Given this list of marker genes Tbc1d4, Furin, Cnksr1, Pi4k2b, Prdm16, Hes1, Ccdc136, Rslcan18, Pdp1, Crcp, Rph3al, here is a description of the gene set: Genes predicted to be targets of miRBase v22 microRNA mmu_miR_8117 in miRDB v6.0 with MirTarget v4 prediction scores > 80 (high confidence targets). species: Mus musculus from publication Chen Y, Wang X (PMID 31504780) Mouse Gene Set: MIR_8117